Given this list of marker genes NEUROG3 (NCBI Gene Id 50674), REL, SPRY4, LMO4, FIGNL1, ZW10, KIFC1, NODAL, RHOF, FKBP9, MTUS1, NECTIN1, PRLR, ITGB3BP, ASB11, H1-6, SPINK2, EDEM1, L3MBTL3, DDX17, ANXA11, FEM1B, MINDY3, DCP1B, DPPA4, SETD5, CHIA, TFPI, MGAT3, PCCB, PPP3CC, IFNA13, ANKRD6, ADAP1, H4C3 (NCBI Gene Id 8364), RO60 (NCBI Gene Id 6738), RBPJ, BMPR2, KLHL15, VAV3, TUBB3, SPINDOC, LRRTM2, RBFOX2, GSTA2, CLCN3, PSME4, OSBPL9, TBC1D13, ZIC3, GADD45A, CCDC68, CXorf38, WSB1, PCYT1B, RCHY1, GDAP1L1, DBF4, SEPSECS, ASF1A, EDC4, SFPQ, ATOH1, ZFP37, ENTPD1, TRMT10A, PCNP, ZNF136, SRSF5, SLK (NCBI Gene Id 9748), FAM117B, NPM1 (nucleophosmin 1), NAA30, CKMT1B, LAMC2, CASK, UGT1A5, PPP1R10, PURA, BTN2A2, RNF125, CLRN1, PACSIN2, MARCHF6, RCBTB1, MEIS1, POU5F1, SPARCL1, PITX2, RAI14, DENND6A, CENPN, CLEC2D, WNK1, NPY1R, SPTA1, H3C8, PPP1R3B, NEUROD1, IPO7, NFE2L1, ASXL1, GPC6, CLDN14, KNG1, SALL4, GRAP2, CD38, PDLIM1, AKAP1, TGIF1, MSC, RIGI, SALL3, DNAJB6, GOLGA1, ST8SIA1, PNRC2, ZNF428, CST13P, GRIPAP1, HSD17B2, CTSL, PIF1, LPAR4, TOR3A, CD180, UPF3A, RCN1, CBX5, FAM204A, SENP2, UBE2B, FUBP3, RBM5, ABCG2, IBTK, KIF13A, DPH6, SP1, LDB1, TAFA4, GCLM, CENPI, H1-5, IFT57, LYPLA1, FBXO28, SHCBP1, CBX1 (NCBI Gene Id 10951), WSB2, FABP2, VCPKMT, IQUB, MYL12B, REN, SAMTOR, ZBTB2, GRHL3, HOXA4, ACOT9, CCP110 (centriolar coiled-coil protein 110), ETF1, KLF9, PRIMPOL, DIS3L, LEFTY1, HS3ST3B1, GUCA2A, IRGM, CSRNP3, ZNRF3, B3GNT5, NKX1-2, HABP4, COQ9 (NCBI Gene Id 57017), MAP7, MBTD1, STEAP2, CXCR4, GTF2I, PLA2G7, GOT1L1, LMO3, SPAG11B, RMND5A, TM9SF4, CACNA2D1 (calcium voltage-gated channel auxiliary subunit alpha2delta 1), F13B, C2CD5, PSMD7, OR10A5, LRRTM3, SLC27A2, CCT6B (chaperonin containing TCP1 subunit 6B), MLLT3, CHMP4C, ALMS1, PBLD, RBMX, RP1L1, ZSWIM1, SP3, ZFP64, OVOL2, SERPINB6, EFHB, OR8J3, NID2, PLPP1, IST1, RCAN1, PHIP, FAM120C, BIRC2, FOSL1, ZNF93, ELMO1, SLC19A3, IL36G, MAP3K5 (NCBI Gene Id 4217), DEDD, RMND1, EDN2, SOCS5, DMRT3, SHOC2, ATG10, TMOD3, CER1, ACTBL2, UFM1 (NCBI Gene Id 51569), ANAPC5, NR1H3, YAP1, KLHL23 (kelch like family member 23), VCAN, UGCG, NDUFS1, ZRANB1, SULF1, MLLT10, GNRH1, TRH, SLC2A3, HOXB8, TLE3, DRAM2, TFAP2B, RIF1, IPO5, RIC8B, MAP4K3, SRGAP3, WAPL, TEAD1, NKAIN3, CD96, FCRL1, SH3BP4, PPIP5K2, UTP14A, KLHL31, MORF4L2, SPRED2, SFRP1, LYRM2, WNT6, PML, MAP7D3, HUS1, RPS20 (NCBI Gene Id 6224), CIPC, DCTN6, TMEM230, RERG, METTL17, SPINK6, NCOR1, OR7G2 (NCBI Gene Id 390882), BCAR1, IGF2BP1, ETV5, SLC6A1, G6PC2, MRFAP1, HMGXB4, M1AP (NCBI Gene Id 130951), SINHCAF, RBM14, ARL6IP5, GDE1, RAB18, FASTKD2, ITGA3, EIF5A, EFNB2, PALM3, PIP4P2, SNX5, COPG2, EPHA4, OR7E24, SMAD7, CLDN4, ARHGEF3, ZFAND1, LRRC34, STK35, G2E3, MRPL11, SKAP2, ZNF706, GBP5, SLC3A2 (NCBI Gene Id 6520), NSD3, HINT1, IVNS1ABP, TCF7L1, RPS12, OR5W2, ZFAND6, PPIA, SLC25A36, CNOT8, DIPK2A, DPP10, NPY5R, LUZP1, NQO2, ANLN, FAM162A, TCEAL8, TBL1XR1, CNOT10, EMILIN2, MMP11, IFNA14, CREB3L2, LBR, FUNDC2, BCL10, SPTBN1, NOSTRIN, B3GNT2, COL6A4P1, SPP1, INAVA, GAD2, PPP1R15B, GABPB1, EIF1AY, PCLO, CGGBP1, ARHGAP12, TSPAN9, OBSL1, NRSN1, MTCL3, RTN3, ZBTB41, NSMAF, FOXD3, TFDP2, ABCA4, TMEM67, ADAMTS6, COL5A2, TRIM5 (tripartite motif containing 5), BARD1, SLC25A3, PHTF2, VANGL1, C9orf153, PARD3, CEP120, TTLL4, ZNF189, RFX4, ARID5B, NDUFA5, TNFRSF19, EMB, GPR152, ALDH3A2, OR5K4, TBC1D9, NPTN, LHFPL6, CD274, IRAG2, IFNK, GPR19, TGM3, CMAS, TMEM26, VDAC3, SPIN1, CD55, SAMM50, TBX18, CTNNB1, DCUN1D3, HLF, ID2, ASRGL1, ADAM23 (NCBI Gene Id 8745), EPCIP, IER2, CBX7, INO80B, SDCCAG8, MLLT6, GAD1, INO80, TIMP4 (TIMP metallopeptidase inhibitor 4), OR5P2, PIPOX, IDUA, HDAC9, OR5H15 (olfactory receptor family 5 subfamily H member 15), ITPK1, SYPL2, MCTS1, CITED2, EPN2, MCEE, OSR2, TCEA1, CCDC88A, RHBDD2, BLTP2, SOX30, FAM107B, SELENOI, GPBP1L1 (GC-rich promoter binding protein 1 like 1), CD47, RNF146, PEF1, TMEM39A, NDC1, BRPF1, TOP3B, MPZL1, RTN1, ANKRD10, C9orf40, EFCAB2, H2BC13, DMTN (dematin actin binding protein), GDAP1, MAT2B, OLIG3, CDC7, PNPLA8, NKIRAS2, YARS2, SHISA2, FUT9, GSDMA (NCBI Gene Id 284110), TUBB2B, HES1, ARHGAP11A, ZCRB1, LIPT1, PRR13, TRA2A, PRRC2A, DNAH14, ARHGAP28, NCK1, EZH2, PAX6, ATCAY, KIT, AOX3P (NCBI Gene Id 107126360), PTCH2, CR1L, CPEB2, UBE2E3, CCDC60, GAP43, OSBP, ANKRD55, SELENOH, RB1CC1, SNX16, FBXW10, PORCN (NCBI Gene Id 65017), INA, VN1R4, RTN4, KRCC1, BMP4, ASPA, ZNF219, CASP3, RUSC2, OSTF1, LRRCC1, CFAP95, ATF2, NFE2L2, ITGA9, DST, NAT1, BBS4 (Bardet-Biedl syndrome 4), ABLIM1, PTPN12, PPP2CA, FBXO32, MOAP1, MLH3, TEX36, LRRN2, TMPRSS7, VN1R5, PTMS, UTP4, RBBP7, KNL1, ZNF484, OR2Y1, LMNTD1, RBPMS, LEFTY2, NLRP4, here is a description of the gene set: Human Gene Set: RAO_BOUND_BY_SALL4_ISOFORM_B studied in species Mus musculus Murine embryonic stem (ES) cells are defined by continuous self-renewal and pluripotency. A diverse repertoire of protein isoforms arising from alternative splicing is expressed in ES cells without defined biological roles. Sall4, a transcription factor essential for pluripotency, exists as two isoforms (Sall4a and Sall4b). Both isoforms can form homodimers and a heterodimer with each other, and each can interact with Nanog. By genomewide location analysis, we determined that Sall4a and Sall4b have overlapping, but not identical binding sites within the ES cell genome. In addition, Sall4b, but not Sall4a, binds preferentially to highly expressed loci in ES cells. Sall4a and Sall4b binding sites are distinguished by both epigenetic marks at target loci and their clustering with binding sites of other pluripotency factors. When ES cells expressing a single isoform of Sall4 are generated, Sall4b alone could maintain the pluripotent state, although it could not completely suppress all differentiation markers. Sall4a and Sall4b collaborate in maintenance of the pluripotent state but play distinct roles. Our work is novel in establishing such isoform-specific differences in ES cells. Loci bound exclusively by SALL4 isoform b in ES cells (embryonic stem). from publication Rao S, Zhen S, Roumiantsev S, McDonald LT, Yuan GC, Orkin SH (PMID 20837710)